The following is a description of a gene set: The process in which a relatively unspecialized cell of the ectoplacental cone acquires specialized features of a spongiotrophoblast of the placenta. A spongiotrophoblast cell is a basophilic cell. studied in species Mus musculus Mouse Gene Set: GOBP_SPONGIOTROPHOBLAST_DIFFERENTIATION, and this is the list of marker genes: Xist, Ascl2, Gjb5, Lif, Hectd1